Given this list of marker genes CCZ1, RMC1, CCZ1B, MON1B, MON1A, here is a description of the gene set: Human Gene Set: GOCC_MON1_CCZ1_COMPLEX species: Homo sapiens A protein complex that functions as a guanine nucleotide exchange factor (GEF) and converts Rab-GDP to Rab-GTP. In S. cerevisiae, this complex consists of at least Mon1 and Ccz1, and serves as a GEF for the Rab Ypt7p.